The following is a description of a gene set: studied in species Mus musculus Mouse Gene Set: REACTOME_SIGNALING_BY_FGFR2 Signaling by FGFR2, and this is the list of marker genes: Fgf9, Polr2d, Fgf20, Ubb, Plcg1, Ubc, Polr2i, Spry2, Sos1, Mapk1, Gtf2f1, Ptbp1, Shc1 (src homology 2 domain-containing transforming protein C1), Hnrnpa1, Mknk1, Fgf1, Polr2l, Fgf10, Ncbp2, Fgf8, Pik3ca, Ptpn11, Polr2e, Polr2h, Grb2, Fgf7, Polr2f, Fgf18, Fgf23, Polr2g, Fgf22, Kras, Ncbp1, Polr2b, Uba52rt, Mapk3, Src, Cbl, Fgf17, Gtf2f2, Ppp2ca, Frs3, Fgf16, Polr2k, Pik3r1, Fgfbp1, Fgf6, Ppp2r1a, Polr2a, Fgf4, Fgf5, Gab1, Ppp2cb (NCBI Gene Id 52429), Braf, Fgfbp3, Frs2, Fgf2, Hras, Uba52, Fgf3, Polr2c (NCBI Gene Id 20021), Rps27a